Given this list of marker genes NFKBIB, RELA, IRF3, POLR2E, CGAS, NFKBIA, IRF7, MYD88, POLR3A, DHX36, RIPK1, POLR3D, POLR1D, DTX4, NKIRAS2, POLR3E, POLR3H, ZBP1, LRRFIP1 (LRR binding FLII interacting protein 1), CREBBP, POLR2F, TBK1, POLR3F, TREX1, POLR3B, POLR3C, TRIM56, POLR2H, POLR1C, XRCC5, NKIRAS1, MRE11, TLR3, DHX9, POLR3G, RPS27A, TRIM21, CHUK, POLR3K, RIPK3, DDX41, POLR2L, EP300, CRCP, IFI16, TRIM32, UBC, IKBKB, UBA52, NLRC3, NLRP4 (NLR family pyrin domain containing 4), STAT6, XRCC6, CTNNB1, UBB, NFKB1, IKBKG, TICAM1, POLR3GL, PRKDC, STING1, AIM2, POLR2K, NFKB2, here is a description of the gene set: part of: Innate Immune System species: Homo sapiens Presence of pathogen-associated DNA in cytosol induces type I IFN production. Several intracellular receptors have been implicated to some degree. These include DNA-dependent activator of interferon (IFN)-regulatory factors (DAI) (also called Z-DNA-binding protein 1, ZBP1), absent in melanoma 2 (AIM2), RNA polymerase III (Pol III), IFN-inducible protein IFI16, leucine-rich repeat flightless interacting protein-1 (LRRFIP1), DEAH-box helicases (DHX9 and DHX36), DEAD-box helicase DDX41, meiotic recombination 11 homolog A (MRE11), DNA-dependent protein kinase (DNA-PK), cyclic GMP-AMP synthase (cGAS) and stimulator of interferon genes (STING).<p>Detection of cytosolic DNA requires multiple and possibly redundant sensors leading to activation of the transcription factor NF-kappaB and TBK1-mediated phosphorylation of the transcription factor IRF3. Cytosolic DNA also activates caspase-1-dependent maturation of the pro-inflammatory cytokines interleukin IL-1beta and IL-18. This pathway is mediated by AIM2. Reactome Pathway: Cytosolic sensors of pathogen-associated DNA